Given this list of marker genes RAC1, GRB2, CDC42, VAV1, PAK2, CD80, CD28, PAK3 (p21 (RAC1) activated kinase 3), CD86, LCK, PAK1, FYN, here is a description of the gene set: Human Gene Set: REACTOME_CD28_DEPENDENT_VAV1_PATHWAY species: Homo sapiens CD28 dependent Vav1 pathway